The following is a description of a gene set: The homeobox gene HOXA5 encodes a transcription factor that has been shown to play important roles in embryogenesis, hematopoiesis, and tumorigenesis. In order to decipher downstream signaling pathways of HOXA5, we utilized oligonucleotide microarray analysis to identify genes that are differentially expressed in HOXA5-induced cells compared with uninduced cells. Comparative analysis of gene expression changes after 9 h of HOXA5 induction in Hs578T breast cancer cells identified genes whose expression was modulated at least 2-fold. Ten of these genes were also up-regulated by at least 2-fold at 6 h post-induction. The expression of all of these genes was confirmed by semiquantitative reverse transcription-PCR. Among these genes, which are most likely to be direct targets of HOXA5, we initiated an investigation into the pleiotrophin gene by first cloning its promoter. Transient transfection assays indicated that HOXA5 can specifically activate the pleiotrophin promoter. Promoter deletion, chromatin immunoprecipitation assay, and gel-shift assays were performed to show that HOXA5 can directly bind to one binding site on the pleiotrophin promoter. These data strongly suggest that microarray analysis can successfully identify many potential direct downstream genes of HOXA5. Further functional analysis of these targets will allow us to better understand the diverse functions of HOXA5 in embryonic development and tumorigenesis. studied in species Homo sapiens from publication Chen H, Rubin E, Zhang H, Chung S, Jie CC, Garrett E, Biswal S, Sukumar S (PMID 15757903) Genes up-regulated 9 h after induction of HoxA5 expression in a breast cancer cell line. Human Gene Set: CHEN_HOXA5_TARGETS_9HR_UP, and this is the list of marker genes: NEMF, SREK1, LIG4, CDK17, IFI16, SNX5, ZNF451, ATF3, NFKBIE, STRN3, ASNS, MARCHF7, BCL10, CDK7, RLF, ENSG00000240291, DPP8, ZNF14, SFPQ, ZSCAN16, SLTM, SEC24A, TRPC1, RSRC2 (NCBI Gene Id 65117), TNFAIP3, CNOT2, EDRF1, PTBP2, CEBPG, DUSP6, SNAI2, SCYL3, LRIF1, PRKRIP1, ZNF136, BTN2A1, F3, ZNF23, IFRD1, DCLRE1C, RBM39, TBK1, TSC22D2, JUN, KLF10, ZNF331, ETS2, CHD9, MAFF, RABGGTB, CTH, PMAIP1, NEDD9, RELB, MTHFD2L, RCHY1, PTGS2, ZNF222, TDG, EGR1, TNFRSF10B, CCNL1, PELI1 (NCBI Gene Id 57334), ZNF155, PSPC1, EIF5 (eukaryotic translation initiation factor 5), POLR3F, ZNF131, NRBF2, CLEC4A, TBC1D31 (TBC1 domain family member 31), AKAP10, FOXO3, FAM53C, TLK2, ZNF426, GUSBP3, PNRC2, ZNF557, ZCCHC8, BACH1, AKIRIN1, ZNF432, PPWD1, NFKBIA, SCG5, CASP3, ZNF45, CEP76, TSC22D1, ARIH1, IP6K2, FOSL2, THSD1, CLK4, ZNF267, FOSB, RIC8B, CREB5, ZNF468, KLF6, CDKN2AIP, PRPF38B, TNFRSF9, IER2, VEGFA, MCL1, WAC, TAF1A, RCAN1, LIF, ADNP, FNBP4, BDKRB1, YY1AP1, DNAJC2, PTPN2, LINS1, SMCHD1, C2orf42, FBXO38, DUSP8, AFG2B, ZNF274, TAF1D (TATA-box binding protein associated factor, RNA polymerase I subunit D), CROCCP2, TBX3, ZNF184, NFIL3, TPTE, ZNF227, ZZZ3, SAT1, BMAL1, RNF111, GAD1, BIRC3, ODR4, DLX2, CEBPB, KDM3A, MARK3, RBM15, SOX30, TUFT1, JMJD1C, BIRC2, TANK, PPIG, KRCC1, GEM, ZNF44, FEM1C, ZNF280D, CCNT2, CNOT4, RIPK2, SNX16, RBM5, KHDC4 (NCBI Gene Id 22889), ING3, PIBF1, ZNF180, ZNF165, FOS, KLF5, ADPRM, CXCL8, PGS1, ZNF3, GPATCH2, TMEFF1, DAAM1, GABARAPL1, ZCCHC10, KIF18A, ATAD2B, PRPF3, UIMC1, MORC3, DUSP5 (NCBI Gene Id 1847), INTS6, PLG, CRY1, NCOA3, PYROXD1, VCPKMT, KIN, SETDB1, CHAC1, NEK1, TIPARP, RBBP6, C21orf91, ZNF195, DMTF1, TUT7, CENPC, CARS1, ZNF20, THAP9-AS1, GADD45B, FAM13B, IRF7, JUNB, SUPT20H, CAB39 (calcium binding protein 39), ARID4B, ZNF107, CLK1, SRSF10, PPP1R12A, KMT5B, ALG13, ZNF112, HRH1, TAF2, NUP58, HLX, STC2, NOC3L, AVL9 (AVL9 cell migration associated), CREM, THUMPD2, RYBP